Given this list of marker genes F12, Proz, F10, Pros1, Serpina5, Adamts13, Sdc3, Ano5 (NCBI Gene Id 233246), Serpine2, Proc, Serpina10, Pf4, Serpind1, Gpc3, Sdc1, Smpd1, Kng2, Gp1bb, F9, F8, Gp9, Klkb1, Serping1, Prtn3, F2, Gp1ba, F7, Cd177, Gpc2, here is a description of the gene set: This event has been computationally inferred from an event that has been demonstrated in another species.<p>The inference is based on the homology mapping from PANTHER. Briefly, reactions for which all involved PhysicalEntities (in input, output and catalyst) have a mapped orthologue/paralogue (for complexes at least 75% of components must have a mapping) are inferred to the other species. species: Mus musculus part of: Coagulation pathway electronically inferred by orthology from the curated human pathway Reactome Pathway: Regulation of clotting cascade